The following is a description of a gene set: Mouse Gene Set: CUI_NEUTROPHIL_IL1B_RESPONSE_DN species: Mus musculus Cytokines mediate cell-cell communication in the immune system and represent important therapeutic targets. A myriad of studies have highlighted their central role in immune function, yet we lack a global view of the cellular responses of each immune cell type to each cytokine. To address this gap, the authors created the Immune Dictionary, a compendium of single-cell transcriptomic profiles of more than 17 immune cell types in response to each of 86 cytokines (>1,400 cytokine-cell type combinations) in mouse lymph nodes in vivo. A cytokine-centric view of the dictionary revealed that most cytokines induce highly cell-type-specific responses. For example, the inflammatory cytokine interleukin-1β induces distinct gene programmes in almost every cell type. A cell-type-centric view of the dictionary identified more than 66 cytokine-driven cellular polarization states across immune cell types, including previously uncharacterized states such as an interleukin-18-induced polyfunctional natural killer cell state. Genes negatively differentially expressed in cell type: Neutrophil upon treatment with cytokine: IL-1β in mouse lymph nodes in vivo. from publication Cui A, Huang T, Li S, Ma A, Pérez JL, Sander C, Keskin DB, Wu CJ, Fraenkel E, Hacohen N (PMID 38057668), and this is the list of marker genes: Ipcef1, Ccrl2, Atxn7, Fos, Fau, Txn1, Sorl1, Jund (jun D proto-oncogene), Cd52, Pmaip1, Fgl2, Gm2a, Lypla2, Slc43a2, Rbm38, Ndufa7, Ier2, Arhgap15, Ncf1, Dcun1d1, Lsp1, Ptprc, Atp5f1e, Hexa, Atox1, Crlf3, Mpeg1, Celf2, Cd101, Cxcr4, Cotl1, Cbl, Ftl1, Gngt2, Tgfbi, Myo1f, Msrb1, Tnfaip2, Srpk2, Pbxip1, Rassf3, Card19, Tyrobp, Retreg1, Stk17b, Ptgs2, Ppp3ca, Gsn, Ttyh3, Itga4, Cd300a, Dhrs7, Csf3r, Prr5l, Scnn1a, Creg1, Junb, Il1b, Fyb1, Rgs2, Grk2 (NCBI Gene Id 11557), Btg2, H2bc4, Cst3, Lst1, Arrdc3 (NCBI Gene Id 105171), Plcg2, Hcar2, Rnf149, Pglyrp1, Clip1, Nr4a1, Zfp36, Taldo1